Given this list of marker genes Mbd4, Pinx1, Orc1, Usp17le, Kif14, Cenpf, Rad21, Brcc3, Cdk1, Atm, Zfyve19, Mbtps2, Wnt10b, Usp50, Stox1, Uimc1, Plk1, Nabp1, Cdc7, Inip, Rnaseh2b, Aven, Pkia, Bard1, Rrm2b, Kcnh5, Trp53, Nbn, Nae1, Creb3l1, Trim39, Babam1, Etaa1, Gpr132, Blm (Bloom syndrome, RecQ like helicase), Ccnb1, Donson, Pbx1, Paxip1, Fhl1, Sin3a, Cdk6, Hspa2, Brd4, Prkcq, Pagr1a, Brca1, Stk35, Vps4b, Dtl, Cdc25a, Cdk5rap3, Mre11a, Mbtps1 (membrane-bound transcription factor peptidase, site 1), Ccnb1-ps, Rcc2, Chek1, Rrm1, Topbp1, Aurkb, Rint1, Ints3, Hacd1, D7Ertd443e, Nabp2, Brsk1, Taok3, Brcc3dc, Fbxo5, Atf5, Zfp830, Abraxas1, Usp47, Ing4, Camk2d, Rad50, Pdik1l, Rbbp8, Nop53, Ctc1, Clspn, Atad5, Macroh2a1, Rad51b, Hus1b, Chfr, Ier3 (NCBI Gene Id 15937), Wee1, Rab11a, Cdkn1a, Taok2, Atr, Dyrk3, Ticrr, Mrnip, Smarcd3, Syf2, Ccnq, Vps4a, Hus1, Miip, Cdc6, Cdc25b (cell division cycle 25B), Fzr1, Cdk4, Babam2, Nek10, Ccng1, Pabir1, App, Foxo4, Chmp4c, Rad51c, Npm1, Rad17, Lmnb1, Cdc25c, Mta3, Cdk2, Cdk3, Taok1, Ccnd1, Cdk10, Pkmyt1, Foxn3, Cdc14b, here is a description of the gene set: Any signaling pathway that modulates the activity of a cell cycle cyclin-dependent protein kinase to modulate the switch from G2 phase to M phase of the cell cycle. species: Mus musculus Mouse Gene Set: GOBP_REGULATION_OF_CELL_CYCLE_G2_M_PHASE_TRANSITION